The following is a description of a gene set: Mouse Gene Set: GOBP_ERBB4_SIGNALING_PATHWAY The series of molecular signals initiated by binding of a ligand to the tyrosine kinase receptor ERBB4 on the surface of a cell, and ending with the regulation of a downstream cellular process, e.g. transcription. species: Mus musculus, and this is the list of marker genes: Acp4, Bace1, Cadm1, Nrg2, Erbb4, Erbb2, Hbegf, Ereg, Nrg4, Klk8, Adam17, Btc, Nrg3, Adam10, Nrg1